Given this list of marker genes Fmod, Tnrc6b, Kansl1, Sec63, Zfp655, Foxk2, Cfap68, Cdkn2aipnl, Lrrn4, Acss2, Snu13, Hs3st3b1, Hmmr, Gm11780, Tnn, Cfap107, Tmem178b, Kif5a, Otud7a, Foxo3, Clec2i, Dmrt1, Kmt2a, Zfp112, Btbd3, Clnk, Abraxas2, Bmp6, Hspa12a, Arfgap2, Ythdf1, Nhlh2, Borcs7, Treml4, Crybg3, Vamp2, Rasgrf2, Zfp334, Rap2a, Ap2a1 (adaptor-related protein complex 2, alpha 1 subunit), Usf3, Dcun1d1, Brsk2, Usp13, Cstpp1, Ptpn14, Dnase1l2, Uhrf2 (NCBI Gene Id 76468), Man1b1, Plcxd3, Hhip, Cop1, Sorbs2, Tsr1, Gm4791, Rcor1, Afg3l1, Nceh1, Gpc2, Rngtt, Rpgrip1l, Wsb1, Sdc2, Eif4a2, Gm2042, Cd96, Eif2a, Wdr59, Vangl1, Abcc2, Vma21, Agbl3, Peg10, Lmna, Ntng1, 2510009E07Rik, Pard3b, Septin2, Endov, Or51e2, Serpinb11, Eif3j2, Cap1, Usp29, Peds1, Kirrel2, Rnf207, Rimklb, Adam10, Polr3k, D5Ertd579e (DNA segment, Chr 5, ERATO Doi 579, expressed), Asic1, Gpr137c, Mcmbp, Shank2, Cdk12, Ccl21a, Car8, Ptk2, Myd88, Pcgf5, Nxpe3, Slc16a7, Trappc9, Galnt7, Kcnip4, Gadl1, here is a description of the gene set: Mouse Gene Set: MIR_6388 from publication Chen Y, Wang X (PMID 31504780) Genes predicted to be targets of miRBase v22 microRNA mmu_miR_6388 in miRDB v6.0 with MirTarget v4 prediction scores > 80 (high confidence targets). studied in species Mus musculus